Given this list of marker genes Pex5, Pex6, Pex16, Ednrb, Pex14, Chchd4, Ift20, Sec62, Rtn2, Tomm20l, Pex12, Sec61g, Zfand2b, Hspd1, Pex7, Timm50, Tmed10, Pex1, Trim37, Aifm1, Dnajc19, Romo1, Timm17a, Pex10, Bloc1s6, Dtnbp1, Dnajc15, Pex13, Tomm20, Tomm40l, Hpse, Tomm7, Trip11, Prf1, Rab11a (RAB11A, member RAS oncogene family), Abca1, Bcs1l, Srp54c, Grpel1, Bloc1s3, Pex2, C2cd5, Exoc4, Glp1r, Tomm40, Tram1, Usp9x, Fcgr4, Hspa8, Tram2, Srp54a, Tram1l1, Dnlz, Ednra, Tomm70a, Grpel2, Myo5b, AU015836, Gfer, Edn1, Sec61a1, Pex26, Exoc7, Pam16, Pex5l, Sec61b, Timm23, Timm44, Lonp2, Timm17b, Hspa5, Timm21, Sec61a2, Sec63, Bcr, here is a description of the gene set: The process in which a protein is transported across a membrane. species: Mus musculus Mouse Gene Set: GOBP_PROTEIN_TRANSMEMBRANE_TRANSPORT